The following is a description of a gene set: species: Homo sapiens Interaction of hematopoietic progenitors with the thymic stromal microenvironment induces them to proliferate, adopt the T cell fate, and asymmetrically diverge into multiple T lineages. Progenitors at various developmental stages are stratified among different regions of the thymus, implying that the corresponding microenvironments differ from one another, and provide unique sets of signals to progenitors migrating between them. The nature of these differences remains undefined. Here we use novel physical and computational approaches to characterize these stromal subregions, distinguishing gene expression in microdissected tissues from that of their lymphoid constituents. Using this approach, we comprehensively map gene expression in functionally distinct stromal microenvironments, and identify clusters of genes that define each region. Quite unexpectedly, we find that the central cortex lacks distinctive features of its own, and instead appears to function by sequestering unique microenvironments found at the cortical extremities, and modulating the relative proximity of progenitors moving between them. Genes up-regulated in thymus perimedullary cortical region versus the whole medulla. Human Gene Set: GSE18281_PERIMEDULLARY_CORTICAL_REGION_VS_WHOLE_MEDULLA_THYMUS_UP from publication Griffith AV, Fallahi M, Nakase H, Gosink M, Young B, Petrie HT (PMID 20064453), and this is the list of marker genes: CD52, ZYX, GPR20, CLSTN1 (NCBI Gene Id 22883), RTN1, TNFRSF11B, CYP2A7, CYP21A2, TUBB, IL2, PHLDA3, IPO5, ARHGAP28, CLCN7, POGK, PTPRO, INS, BPTF, STEAP3, SPG7, JAG2, BTG2, TMEM109, KLK6, ARHGAP32, SCARA3, ITGA2, SLC41A3, AKAP1, RRAGA, ERAL1, P2RY1, RGS4, CTBP1, CCDC92, SSPN, ERC1, CDCA4, CSN3, MICALL2, DLGAP2, MEN1, RIN1, BRD9, SI, MCM6, AP1M2, ETF1, PCF11, PODXL, MTPAP, BCL9, CARM1, CELSR2, ANGPTL3, COL7A1, RPLP1, SUPT16H, TCF20, PPM1G, DDX39B, LIMK2, GPD1L, TCF7L1, CNTNAP2, PHACTR4, BZW2 (NCBI Gene Id 28969), SRSF9, KRT14, COL17A1, DSTYK, ANKRD11, PKD2L2, RXRA, G6PD, DRP2, KPNA6, IDUA, DCTN1 (dynactin subunit 1), CACNA1D, AKR1B10, IRF5, B3GALT5 (NCBI Gene Id 105372805), APBB1, PSEN1, TBL1XR1, NFATC3, ALDH3A2, IGKC, HLA-C (NCBI Gene Id 5674), EDEM2, RAMP3, DENND1C (NCBI Gene Id 79958), ASIC1, FOXN3, GTPBP8, VPS37A, ALOX12B, NAT10, FCGR2A, ELOCP28, AKR1C1, ZNF589, SLC6A15, GNPDA1, OR1A2, ZNF318, TSC2, MAPKAPK3, OGN, NSG2, HOMER2, RUSC1, ZNF500, DYNC1I1, CD160, ESYT1, GLI3, VPS16, ABCF1, CYP2J2, AAK1, VCL, GSTK1, TSPAN14, CTSD, ALDH9A1, PIAS3, ZNF609, ADCY10, PLEKHA1, EPHB6, ZFHX3 (zinc finger homeobox 3), MAB21L4, GEMIN4, DAPK2, APLP2, B3GNT3, VPS28, MRPS27, ADGRE1, CELSR1, BMP2K, INHBB (inhibin subunit beta B, NCBI Gene Id 3625), GAL, PAPSS1, FAM86B1, SP3P, ADGRG1 (NCBI Gene Id 9624), NSD1 (nuclear receptor binding SET domain protein 1), SPON2, RSAD2, DDX56 (DEAD-box helicase 56), IMPDH2, FHOD1, TBCB, LHX6, NEIL3, NEUROD6, NOTCH1, SAE1, SERPING1, AAR2, INTS1, DCC, ERBB2, CYTL1 (NCBI Gene Id 54360), CEBPA, CHD8, CHD1L, SOBP, KRT5, CILP, LRRC14, EPHX1, FSCN1, ADH1B, SEC14L1P1, SF3A3, UBTF, INF2, TTC23, WSCD1, ITGA3, SDC2, PUM2, FBXW4P1, ADORA1, BICD1, PPP2R2B, ZIC4, AUTS2, STARD5, ANPEP, SFTPB, LEPROT, POU5F1B, RCL1 (RNA terminal phosphate cyclase like 1), MYD88